Given this list of marker genes USP49, USP22, MYSM1, BAP1, USP36, USP3, USP51, USP16, here is a description of the gene set: A deubiquitinase that cleaves ubiquitin from a histone protein to which it is conjugated. studied in species Homo sapiens Human Gene Set: GOMF_HISTONE_DEUBIQUITINASE_ACTIVITY